The following is a description of a gene set: species: Mus musculus The process in which an antigen-presenting cell expresses a peptide antigen of exogenous origin on its cell surface in association with an MHC protein complex. The peptide is typically a fragment of a larger exogenous protein which has been degraded within the cell. Mouse Gene Set: GOBP_ANTIGEN_PROCESSING_AND_PRESENTATION_OF_EXOGENOUS_PEPTIDE_ANTIGEN, and this is the list of marker genes: Clec4a4, Pikfyve, Mfsd6, H2-K1, H2-T23, H2-Oa, Lgmn, H2-DMa, H2-DMb2, B2m, Fcgr3, H2-DMb1, H2-Ob, Cd74, Ctse, H2-Eb2, Clec4a2, H2-Ea, Fcgr1, Ifi30, Mpeg1, H2-M3, Tapbp, Clec4a3, Traf6, Fcer1g, Tap2, Ctss, Unc93b1, Fcgr2b (NCBI Gene Id 98391), H2-Ab1, H2-Eb1, H2-Aa